Given this list of marker genes CDH2, ETS1, LEF1, SNAI2, TWIST2, HMGA2, ACTA2, here is a description of the gene set: from publication Nadella KS, Jones GN, Trimboli A, Stratakis CA, Leone G, Kirschner LS (PMID 18413734) Dysregulation of protein kinase A (PKA) activity, caused by loss of function mutations in PRKAR1A, is known to induce tumor formation in the inherited tumor syndrome Carney complex (CNC) and is also associated with sporadic tumors of the thyroid and adrenal. We have previously shown that Prkar1a(+/-) mice develop schwannomas reminiscent of those seen in CNC and that similar tumors are observed in tissue-specific knockouts (KO) of Prkar1a targeted to the neural crest. Within these tumors, we have previously described the presence of epithelial islands, although the nature of these structures was unclear. In this article, we report that these epithelial structures are derived from KO cells originating in the neural crest. Analysis of the mesenchymal marker vimentin revealed that this protein was markedly down-regulated not only from the epithelial islands, but also from the tumor as a whole, consistent with mesenchymal-to-epithelial transition (MET). In vitro, Prkar1a null primary mouse embryonic fibroblasts, which display constitutive PKA signaling, also showed evidence for MET, with a loss of vimentin and up-regulation of the epithelial marker E-cadherin. Reduction of vimentin protein occurred at the posttranslational level and was rescued by proteasomal inhibition. Finally, this down-regulation of vimentin was recapitulated in the adrenal nodules of CNC patients, confirming an unexpected and previously unrecognized role for PKA in MET. Human Gene Set: NADELLA_PRKAR1A_TARGETS_DN studied in species Mus musculus Epithelial and mesenchymal markers down-regulated in MEF cells (embryonic fibroblasts) after knockout of PRKAR1A.